The following is a description of a gene set: Any process that modulates the rate, frequency or extent of neutrophil mediated killing of a target cell, the directed killing of a target cell by a neutrophil. species: Homo sapiens Human Gene Set: GOBP_REGULATION_OF_NEUTROPHIL_MEDIATED_CYTOTOXICITY, and this is the list of marker genes: POMC, DNASE1L3, F2RL1, DNASE1, ARG1, CXCL6